Given this list of marker genes Tmbim6, Eno1b, Map2k1, Eno1, Pik3cb, Pink1, Nol3, Zfas1 (NCBI Gene Id 68949), Hyou1, Kdm6a, here is a description of the gene set: Any process that modulates the frequency, rate or extent of hypoxia-induced intrinsic apoptotic signaling pathway. Mouse Gene Set: GOBP_REGULATION_OF_HYPOXIA_INDUCED_INTRINSIC_APOPTOTIC_SIGNALING_PATHWAY studied in species Mus musculus